Given this list of marker genes FLT4, FOXC1, SOX18, VEGFC, EPHA2, TIE1, PTPN20, SVEP1, CCBE1, FGF2, PROX1, LGALS8, PTPN14, BMPR2, ACVR2B, PPP3CB, VASH1, ACVRL1, PDPN, VEGFA, CLEC14A, PKD1, FOXC2 (NCBI Gene Id 50824), MIR9-1, here is a description of the gene set: The process in which the anatomical structures of lymph vessels are generated and organized. The lymph vessel is the vasculature carrying lymph. studied in species Homo sapiens Human Gene Set: GOBP_LYMPH_VESSEL_MORPHOGENESIS